Given this list of marker genes RAB8A, SLC9A8, RAB13, HLA-DRB5, NDST1, ATXN2, SLC30A6, DENND5A, ARL5C, VPS54, LAMP2, AP1B1, HLA-DPA1, MARCHF1, BICD1, AZIN2, PI4K2B, CLVS1, CHID1, PHAF1, GPR108, ATP8A1, AP1S2 (NCBI Gene Id 8905), VPS13B, AFTPH, LAP3, AP4S1, AP4E1, PIK3C2A, DOP1A, C17orf75, WLS, CCDC186, PREPL, RAB11A, LGR5, NMNAT2, RAB9A, SLC2A4, CD2AP (CD2 associated protein), CD74, CLVS2, CLASP2, HLA-DRA, TAS2R16, ATP8B3, SORL1, VTI1A, KLHL20, CABP7, ARL5B, SLC9A7, GRN, SLC11A2, GOLPH3, RABEPK, ATP8B1 (NCBI Gene Id 5205), NSG2, TGFBI, CHST6 (carbohydrate sulfotransferase 6), STX8 (NCBI Gene Id 9482), SLC66A2, ATP8B4 (ATPase phospholipid transporting 8B4 (putative)), WDR11, RAB14, MYO18A, TRAPPC9, CHAC1, PLOD3, CHST2, FUT4, ARAP1, PI4K2A, STX6, WIPI1, SNX9, GGA1, SYT17, MYO1B, YIPF1, COG3, HLA-DRB1, RIC1, TJAP1, APP (NCBI Gene Id 351), MLANA, ATP8B2, CDH1, SYS1, SCAMP2, LGR6, RAB6A, GOLPH3L, RAB21, HLA-DQA2, TMEM79, ATG9A, AP1S1, HLA-DQA1, LLGL1, BACE1 (NCBI Gene Id 23621), FCMR, PLEKHA8, GCNT1, ARFIP1, MME, SCAMP3, SYT11, BACE2, YIPF6, CCDC91, RHOBTB3, VAMP5, PLD4, MICALL1, GPER1, ELAPOR1, HLA-DRB4, COG7, ATP7A, OSBP, PLEKHA3, PRKD1, DOP1B, HLA-DQB1, COG1, TRAPPC6B, MS4A7, GBA1, TEPSIN, ST3GAL1, CBY1, COG8, FAM91A1, CLN3, RAC1, CALN1, USP6NL, COG6, MMP24, VPS53, NSG1, SCAMP5, ATP7B (ATPase copper transporting beta), RAB38, CLTCL1, DNAAF6, INPP5K, PCSK5, VAMP4, YIPF2, AP4M1, COG5, PHETA1, AP1M2, GOLT1A, STX10, TPST2, TGOLN2, SCAMP4, ECPAS, MS4A6E, BPNT2, SLC35B2, VAMP2, GOLGA1, ATG9B, PICK1, ATP8A2, ARFIP2, RBFOX1 (NCBI Gene Id 54715), RAB31, LRRK2, RAB30, VAMP3, BIRC6, VPS51, NBEA, OPTN, GOLGA4, TMEM165, SLC39A9, ATP2C2, AP1S3, BAIAP3, RELCH, ATP9A, RGS20, HTR7, CIMAP3, PLPP3, STX16, M6PR, ARFRP1, FUT9, KIAA0319L, PCSK7, SLC24A5, SCAMP1, AP1M1, STX4, CHST5, VAMP7, CLTC, RAB32, GGA3, RGP1, CLBA1, CLTA, PLEKHJ1, ATP9B, ASAP1, YIPF5, HOOK2, SLC30A5, MS4A6A, TBC1D23, FURIN, SNAP25, RAB29, CHST4, FUT7, RAB7B, RAB10, TRAPPC6A, TMEM230, GSAP, GCC2 (NCBI Gene Id 9648), HLA-DRB3, TPST1, PCSK1N, CORO7, BOK, IGF2R, YIPF7, CRACR2A, COG2, DPY30, RAB43, PCSK4, EIPR1, GBF1, MARCHF9, MARCHF4, RAB11FIP3, SCOC, AP4B1, CNST, CA4, COG4, SMPD4, KIF13A, PHETA2, GGA2, ARFGEF2, ARFGEF1, HLA-DQB2, ARL1, HLA-DPB1, CLIP3, ATP2C1, AP1G1, VPS52, CLTB, GNAS, POSTN, BECN1, OCRL, ARL5A, YIPF4, here is a description of the gene set: The network of interconnected tubular and cisternal structures located within the Golgi apparatus on the side distal to the endoplasmic reticulum, from which secretory vesicles emerge. The trans-Golgi network is important in the later stages of protein secretion where it is thought to play a key role in the sorting and targeting of secreted proteins to the correct destination. species: Homo sapiens Human Gene Set: GOCC_TRANS_GOLGI_NETWORK